The following is a description of a gene set: Citric acid cycle (TCA cycle) species: Homo sapiens Human Gene Set: REACTOME_CITRIC_ACID_CYCLE_TCA_CYCLE, and this is the list of marker genes: IDH3G, FXN, IDH3A, SDHAF4, ISCU, ISCA1, IDH2, NFS1, SDHAF2, LYRM4, SDHAF1, SUCLG2, DLD, SDHD, MDH2, TRAP1, SIRT3, OGDH, ACO2, SDHC, DLST, IDH3B, NNT, SUCLA2 (succinate-CoA ligase ADP-forming subunit beta), CS, SUCLG1, SDHB, SDHA, SDHAF3, ISCA2, FH, KGD4, CSKMT, ACAT1